The following is a description of a gene set: The process whose specific outcome is the progression of a megakaryocyte cell over time, from its formation to the mature structure. Megakaryocyte development does not include the steps involved in committing a cell to a megakaryocyte fate. A megakaryocyte is a giant cell 50 to 100 micron in diameter, with a greatly lobulated nucleus, found in the bone marrow. studied in species Homo sapiens Human Gene Set: GOBP_MEGAKARYOCYTE_DEVELOPMENT, and this is the list of marker genes: THPO, WASF2 (WASP family member 2), GP9 (glycoprotein IX platelet), PIP4K2A (NCBI Gene Id 5305), MPIG6B, VPS33B, TAL1, ABI1, SRF, FLNA, ZFPM1, GP1BB, PTPN11, EP300, SH2B3, MEIS1, KIT, GP1BA, FLI1, PTPN6, GP5, ZNF385A, MED1